Given this list of marker genes PHYH, HACL1, ALDH3A2, SLC27A2 (NCBI Gene Id 8523), SLC25A17, PECR, here is a description of the gene set: Alpha-oxidation of phytanate studied in species Homo sapiens Human Gene Set: REACTOME_ALPHA_OXIDATION_OF_PHYTANATE